Given this list of marker genes BANK1, EFHC2, IGHG1, AMMECR1, TSPAN13, MS4A1, SPTBN1, here is a description of the gene set: Genes up-regulated in blood responders vs poor responders in seniors (65-81) (responders (training set)) after exposure to Twinrix, time point 0D. Comment: Network inference based on the 15 markers identified as predictors of the response to the HBV vaccine. Human Gene Set: FOURATI_BLOOD_TWINRIX_AGE_65_81Y0_RESPONDERS_VS_POOR_RESPONDERS_TRAINING_SET_0DY_NETWORK_INFERENCE_UP species: Homo sapiens Aging is associated with hyporesponse to vaccination, whose mechanisms remain unclear. In this study hepatitis B virus (HBV)-naive older adults received three vaccines, including one against HBV. Here we show, using transcriptional and cytometric profiling of whole blood collected before vaccination, that heightened expression of genes that augment B-cell responses and higher memory B-cell frequencies correlate with stronger responses to HBV vaccine. In contrast, higher levels of inflammatory response transcripts and increased frequencies of pro-inflammatory innate cells correlate with weaker responses to this vaccine. Increased numbers of erythrocytes and the haem-induced response also correlate with poor response to the HBV vaccine. A transcriptomics-based pre-vaccination predictor of response to HBV vaccine is built and validated in distinct sets of older adults. This moderately accurate (area under the curve ~65%) but robust signature is supported by flow cytometry and cytokine profiling. This study is the first that identifies baseline predictors and mechanisms of response to the HBV vaccine. from publication Fourati S, Cristescu R, Loboda A, Talla A, Filali A, Railkar R, Schaeffer AK, Favre D, Gagnon D, Peretz Y, Wang IM, Beals CR, Casimiro DR, Carayannopoulos LN, Sékaly RP (PMID 26742691)